Given this list of marker genes SLC24A4, GRK1, TTR, GNAT1, NR2E3, NMT2, LRIT1, RP1, OPN1LW, PNPLA2, GNAQ, OPN1MW2, OPN1MW3, GNAT3, OPN4, GNGT1, RGR, GRK4, GNAT2, GNGT2, OPN1MW, GUCY2F, CDS1, AIPL1 (NCBI Gene Id 23746), CAMKMT, RBP4, OPN5, OPN3, PCP2, UNC119, PLEKHB1, CABP4 (NCBI Gene Id 57010), GRK7 (G protein-coupled receptor kinase 7), RRH, OPN1SW, GNA11, RCVRN, PDE6B, SAG, ABCA4, SLC24A2, GPR52, CNGB1, GPR88, GUCA1ANB-GUCA1A, GUCA1B (NCBI Gene Id 2979), GUCA1A, PDC, TRPC3, GUCY2D, PITPNM1, RHO, NMT1, PDE6C, ASIC2, here is a description of the gene set: The sequence of reactions within a cell required to convert absorbed photons into a molecular signal. Human Gene Set: GOBP_PHOTOTRANSDUCTION species: Homo sapiens